Given this list of marker genes SIRT1, RRP8, SUV39H1, BAZ2A, NOP53, here is a description of the gene set: species: Homo sapiens Human Gene Set: GOCC_RDNA_HETEROCHROMATIN A region of heterochromatin located at the rDNA repeats in a chromosome.